The following is a description of a gene set: from publication Yevshin I, Sharipov R, Kolmykov S, Kondrakhin Y, Kolpakov F (PMID 30445619) Genes containing one or more binding sites for (MDM2) in their promoter regions (TSS -1000,+100 bp) as identified by GTRD version 20.06 ChIP-seq harmonization. species: Homo sapiens Human Gene Set: MDM2_TARGET_GENES, and this is the list of marker genes: FTL, HEXIM1, BRD2, ADM, INTS6, INTS6-AS1, POLR2A, IER3 (immediate early response 3), KMT2A, SNX12, FUS, ZBTB4, UBB